The following is a description of a gene set: Human Gene Set: GOBP_ANTIGEN_PROCESSING_AND_PRESENTATION_OF_PEPTIDE_OR_POLYSACCHARIDE_ANTIGEN_VIA_MHC_CLASS_II studied in species Homo sapiens The process in which an antigen-presenting cell expresses antigen (peptide or polysaccharide) on its cell surface in association with an MHC class II protein complex., and this is the list of marker genes: FCGR2B, TREM2, HLA-DQB2, THBS1, CTSL, LGMN, CTSF, HLA-DMA, UNC93B1, HLA-DQB1, HLA-DMB, HLA-DRA, HLA-DRB5, FCER1G, B2M, HLA-DRB1, MARCHF8, PYCARD, HLA-DPB1, DNM2, HLA-DQA2, PIKFYVE, MARCHF1, TRAF6, HLA-DRB3, CTSE, CD74, HLA-DQA1, CTSS, HLA-DRB4, ARL8B, CTSV, IFI30 (NCBI Gene Id 126359), HLA-DPA1, CTSD, HLA-DOA, HLA-DOB